Given this list of marker genes Psap, Serpina3g, Ewsr1, H2-D1, H2-K1, Tapbp, here is a description of the gene set: Cytokines mediate cell-cell communication in the immune system and represent important therapeutic targets. A myriad of studies have highlighted their central role in immune function, yet we lack a global view of the cellular responses of each immune cell type to each cytokine. To address this gap, the authors created the Immune Dictionary, a compendium of single-cell transcriptomic profiles of more than 17 immune cell types in response to each of 86 cytokines (>1,400 cytokine-cell type combinations) in mouse lymph nodes in vivo. A cytokine-centric view of the dictionary revealed that most cytokines induce highly cell-type-specific responses. For example, the inflammatory cytokine interleukin-1β induces distinct gene programmes in almost every cell type. A cell-type-centric view of the dictionary identified more than 66 cytokine-driven cellular polarization states across immune cell types, including previously uncharacterized states such as an interleukin-18-induced polyfunctional natural killer cell state. Mouse Gene Set: CUI_CDC1_BAFF_RESPONSE_UP Genes positively differentially expressed in cell type: cDC1 (conventional dendritic cell type 1) upon treatment with cytokine: BAFF in mouse lymph nodes in vivo. studied in species Mus musculus from publication Cui A, Huang T, Li S, Ma A, Pérez JL, Sander C, Keskin DB, Wu CJ, Fraenkel E, Hacohen N (PMID 38057668)